Given this list of marker genes HK1, GCK, PFKM, HK3, PKM, ENO3, BCL2L13, PFKP, PFKL, FOXK2, PGK1, ENO1, PGAM1, TPI1, GPI, PGAM2, ENO2 (NCBI Gene Id 2026), HK2, FOXK1, GALK1, PGK2, ADPGK, here is a description of the gene set: The chemical reactions and pathways resulting in the breakdown of a carbohydrate into pyruvate, occurring through a glucose-6-phosphate intermediate, with the concomitant production of a small amount of ATP. species: Homo sapiens Human Gene Set: GOBP_GLYCOLYTIC_PROCESS_THROUGH_GLUCOSE_6_PHOSPHATE